The following is a description of a gene set: Any process that activates or increases the frequency, rate or extent of a process that affects and monitors the activity of telomeric proteins and the length of telomeric DNA. species: Homo sapiens Human Gene Set: GOBP_POSITIVE_REGULATION_OF_TELOMERE_MAINTENANCE, and this is the list of marker genes: MAPK3, RAD50, TFPT, TNKS2, PML, SLX4, CCT2, HNRNPA1, NFRKB, TNKS, MYC, MRE11, MAP2K7, PNKP, YY1, HSP90AA1, INO80C, ACD, NBN, SIRT6, PPP1R10, RTEL1, ATR, MAPKAPK5, GNL3, ACTR5, AURKB, NAF1, TINF2, RUVBL1 (NCBI Gene Id 8607), ATM, KLF4, TERF2, FBXO4, ACTL6A, MAPK15 (mitogen-activated protein kinase 15), DHX36, CTNNB1, UCHL5, CCT5, HNRNPA2B1, MCRS1, ERCC1, SLX1B, TERF2IP, MAPK1, HNRNPD, TERF1, ACTR8, DKC1, PTGES3, PKIB, CCT3, INO80, INO80D, NVL, INO80E, CCT8, TCP1, NABP2, CCT4, WRAP53, ATRX, RUVBL2, INO80B, NEK2, NEK7, POT1, PRKCQ, MAP3K4, CCT7, PARN, SLX1A, CCT6A